Given this list of marker genes EMP1, ESAM, DDX3X, MX1, EGR1, ATP1B3, RCAN1, IFIT1, CTNNB1, NFE2L2, PER2, ELF1, RBM8A, FUS, CYYR1, H2AZ1, ZC3HAV1, RNF122, U2AF1, VWA1, STX12, HSP90AB1, GADD45B, IFITM1, RAP1B, IDI1, SRGN, SERTAD3, TM4SF18, STC2, BTG2, FAM13C, RBM7, NNMT, CYP51A1, H3-3B, LRRC32, CEBPD, PICALM, VASP, SERTAD1, CDK17, ELOC, BCL10, RNF138, NR4A2, H3P6, RAB5A, SOS1 (NCBI Gene Id 7838), SPARCL1, DDX5, EIF3J, CXCL12, ABL2, IFITM2, APOLD1, SNX3, ARF4, THBD (thrombomodulin), ITM2A, CYCS, LMCD1, DLC1, RPL17, CD36, LPAR6, SCGB3A2, HNRNPH1, WARS1 (NCBI Gene Id 7453), MIR22HG, FAM110D, NEDD9, INSIG1, NIP7, PLPP3, RBPMS, MAFF, ENPP2, MEF2C, CD34, SOCS3 (NCBI Gene Id 9021), PLSCR1, ADRB1, MYC, C1orf56 (chromosome 1 open reading frame 56), UBE2J1, PLEKHF2, C1orf52, PISD, AHR, DNTTIP2, IRF7, TUBA1B (tubulin alpha 1b), TM4SF1, ACTG1, TMEM70, NAMPT, FOSB, SMU1, TRIB1, TSPAN13 (tetraspanin 13), ACTB, IVNS1ABP, RASGRP3, BHLHE40, ZYX, TMSB15A, ETS2, DIPK2B, RGS1, F8 (NCBI Gene Id 14069), SRSF7, UGCG, DCAF13, BZW1, PFDN2, IRF1, SNAI1, MAGOH, JMJD1C, SARAF, FN1, SPRY1, CDC42EP3 (NCBI Gene Id 10602), CP, TAP1, JUNB, POMP, BMP6, RRP7A, LDHA (NCBI Gene Id 3939), C11orf96 (NCBI Gene Id 387763), ARF6 (ADP ribosylation factor 6), ABCB1, MYCT1, RGCC, HNRNPF, UBC, PLAUR, MLEC, WSB1, IFIT3, SAR1A, ULBP2, KLF10, PRDM1, SLC25A5, SDCBP, RBMX, HSPA8, B3GNT5, TNFRSF12A, CD200, SOX17, COQ10B, MAT2A, C11orf91, UBE2D3, SRSF3, RSL24D1 (ribosomal L24 domain containing 1), HNRNPA1, CDC42EP1, PNP, RPS10, STARD4, FOSL2, MCL1, SERPINH1, RPIA, MRPL33, LYZ, FAM133B, CLIC4, TFPI2, ZFAND5, CCNL1, MYL9, TSC22D1, SNRPD1 (NCBI Gene Id 6632), CFAP20, TUBB4B, EIF1, SNRPB2, TPD52, ADAMTS1 (NCBI Gene Id 9510), EIF4G2, ETV6, HNRNPA2B1, MIDN, XIST, PFKFB3, SFTPC, RND3, ADM, RDX, RAB20, SOCS2, IFI6, ARID5A, CDC42SE1, PIM1, COL15A1, LMNA, CCN1, PPP1R14A, CRHBP, PALMD, ITPRIP, CDKN1A, COX17, RBP7, TSC22D2, ATF3, TPM4, TPSAB1, NR4A1, CSRNP1, YBX3, CYTH2, HBEGF (NCBI Gene Id 1839), SIK1, BAG3, ZFP36, SRSF5, MT2A, APOL4, TAF7, RAPGEF4, C1orf54, CD300LG, FAM43A, BEX5, SUB1 (SUB1 regulator of transcription), GJA1, MGLL, SLC25A25, ILF2, IGLL5, EGR3, SFPQ, HNRNPM, EIF3I, MSX1 (NCBI Gene Id 4487), LDLR, PCDH17, IRF2BPL, PGK1, SWAP70, A2M, STOM, TCF4, RUNDC3B, ZNF593, YWHAH, FMO2, ADAMTS9, KDM6B, SRSF6, IFI16, GNAI3 (G protein subunit alpha i3), SLC2A3, SDE2, CCN2, DDX21, DNAJA1, IFITM3, NPM1, UAP1 (UDP-N-acetylglucosamine pyrophosphorylase 1), GTF2B, CLEC14A, HNRNPDL, COL4A1, here is a description of the gene set: Human Gene Set: TRAVAGLINI_LUNG_BRONCHIAL_VESSEL_2_CELL species: Homo sapiens from publication Travaglini KJ, Nabhan AN, Penland L, Sinha R, Gillich A, Sit RV, Chang S, Conley SD, Mori Y, Seita J, Berry GJ, Shrager JB, Metzger RJ, Kuo CS, Neff N, Weissman IL, Quake SR, Krasnow MA (PMID 33208946)